Given this list of marker genes GSK3B, GCLC, MAF, YES1, PGAM5, GCLM, SRC, RBX1, PRKCA, INSR, NQO1, MAPK8, FYN, EPHB2 (EPH receptor B2), NFE2L2, SLC7A11, PIK3CA, GSTA2, HMOX1, KEAP1, AIMP2, CEBPB, CUL3, here is a description of the gene set: Human Gene Set: WP_NRF2ARE_REGULATION studied in species Homo sapiens NRF2-ARE regulation